Given this list of marker genes Dstn, Arid2, Dnase2b, Ctss (NCBI Gene Id 13040), Smarcd1, Upf1, Smarca4, Add3, Clasp1, Specc1l, Plaat3, Calm1, Ptrh1, Tpx2, Trip4, Nckap5l, Clasp2, Stx17, Ddr1, Taok1, Add2, Tbc1d25, Oga, Calm3, Stmn4, Capza1b, Arhgef2, Ascc3, Myh9, Hpn, Snx14, Kdm4a, Lmod2, Cracd, Ascc2, Capza2, Smarcb1, Gabarapl1, Tnf, Chmp6, Nav3, Ccn2, Map6d1, Itgb1, Pbxip1, Vps16, Ssrp1, Capg, Tecpr1, Trpv4 (transient receptor potential cation channel, subfamily V, member 4), Plekhh2, Atg14, Kif19a, Rpl23, Adamts5, Gbf1, Arid1a (NCBI Gene Id 93760), Fyco1, Diaph3, Becn1, Smarcd3, Iqsec1, Plk3, Hsf1, Fgfr4, Eml4, Camsap3, Atad2, Capza3, Ccsap, Cib1, Denr, Twf1, Kat5, Irak3, Tom1, Twf2, Hbs1l, Dyrk3, Rhoa, Nckap5 (NCK-associated protein 5), Dnase2a (deoxyribonuclease II alpha), Igf1r, Rack1, Hemk1, Pafah1b1, Wdr72, Aurkb (aurora kinase B), Trem2, Acvr1c, Tgfb2, Etf1, H2ac25, Elp6, Gak, Atad2b, Asb17, Vangl2, Chmp7, Chmp1b, Adamts15, Kif18a, Ctsg, Mical2, F2rl1, Top2a, Mfsd8, Prickle1, Trnt1, Cx3cr1, Ufl1, Exog, Fap (NCBI Gene Id 14089), Ltn1, Calm2, Cd47, Insr, Lmod3, Napa, Tcf25, Irgm2, Cdk5rap3, Hspa8, Katnb1, Pym1, Ogfod1, Lcp1, Nsf, Tmem39a, Vrk1, Eif2d, Camsap1, Sh3pxd2b, Svil, Chmp4b, Blcap, Cma1, Col6a1, Kif2c, Akap8l, Cfl1, Map1lc3b, Adrb2, Add1, Chmp2a, Mtrf1, Sema5a, Igtp, Irgm1, Plin2, Mcoln1, Ehbp1l1 (EH domain binding protein 1-like 1), Ankzf1, Plaat1 (phospholipase A and acyltransferase 1), Gsn, Tmod1, Rp1, Chmp1a, Cdk1, Klk5, Lamp2, Atr, Trim58, Gas2l2, Adgrb3, Pik3r1, Map2 (microtubule-associated protein 2), Mical1, Rac1, C1qb, Htt, C1ql1 (NCBI Gene Id 23829), Gata5, Trim21, Hnf1a, Elac1, Plxnc1, Uvrag, Mrpl58, Zfp598, Wnk1, Apc, Hspa2, Skic8, Scaf4, Gas2l1, Lamc1, Mid1ip1, Wdr1, Sptan1, Vmp1, Vil1, Tpm1, Rdx, Aqp2, Sptbn1, Hdgfl3, Ufsp2, Gcn1, Kcnk13, Aurka, Aifm1, Chmp1b2, Plin3, Stmn1, Smarcd2, Avil, Ccdc88c, Tfip11, Rubcnl, Skic3, Bbof1, Ets1, Ppp1r9b, Snai2, Rsph6a, Eef2k, Il1b, Kif14, Abcc8, Vps33a, Septin7, Pdxp, Map1a, Mid1, Tmod3, Synj1, Smcr8 (Smith-Magenis syndrome chromosome region, candidate 8 homolog (human)), H2bc1, Kif9, Spast, Mrrf, Mcts1, Map1b, Apc2, Atg5 (autophagy related 5), Zfand1, Rrp7a, Cst3, Clec16a, Asph, Sh3bp1, Grwd1, Lima1, Ston1, Noxo1, Bok, Stmn2, Ern2, Gabarap, Scin, Fscn1, Ttbk2, Prkaa1, Meltf, Nrg1, Epg5, Dnajc17, Plk1, Smarcc1, Ddit4 (DNA-damage-inducible transcript 4), Tgfbr1, Trim54 (NCBI Gene Id 78173), Afg2b, Dicer1, Tmod4, Pdpn, Rnf14, Pelo, Cidea, Eif5a2, Endog, Apaf1, Tmod2, Cebpg, Vps54, Foxl2 (forkhead box L2), Klhdc10, Rchy1, Mtrfr, Eif5a, Ddrgk1, Kif2b, Sptb, Scaf8, Chmp2b, Eps8, Itgam, Pif1, Sgk1, Smarce1, Abce1, Bax, Stmn3, Ndel1, Bnip3, Klk4, Hdac6, Myc, Mtres1, Vps4a, Map1s, Cdk5, Mmp13, Nedd1, Sharpin, Faf2, Cdkn2a, Nmnat1, Atg12, Skic2, Gspt1, Ckap2, Gabarapl2, Bmerb1, Capzb, Cln3, Zmpste24, Kif21a, Dusp3, Dbnl, Mical3, Kif24, Vcp, Map4k4, Lmod1 (NCBI Gene Id 93689), Vps4b, Epha4, Pik3c3, Tnp1, Mtif3 (NCBI Gene Id 76366), Atp2a2, Smn1, Dedd2, Supt16, Capza1 (capping actin protein of muscle Z-line subunit alpha 1), Smarcc2, Chmp4c, Chka, Acin1, Kif5b, Mapre2, Dpp4, Flot1 (NCBI Gene Id 14251), Dctn1, Eng (endoglin), Cd24a, Arf6, C1qc, Snap29, Stx5a, Ddr2, Ngef, Evl (NCBI Gene Id 14026), Kif18b, Mmp20, Gspt2, Gper1, Pex14, Htr1a, Wdr47, Fgf13, Bloodlinc, Ubqln1, Pex5, Lix1l, Nemp1, Rac2, Dmtn, Golga2 (NCBI Gene Id 99412), Mylk3, Traf2, Carmil2, Pnpla2, Fer, Vill, Akap5 (NCBI Gene Id 70774), Arpc2, Vamp8, Dnase1l3, Map1lc3a, Gba1, Pik3r4, Atxn7, Setx, Pik3ca, Swap70, C3, Blvra, Per2, Eif4e2, Saysd1, Calcoco2, Spef1, Klc1, Dffa, Dnajc6, Phf23, Chmp5, Exoc8, Chmp3, Map4, Camsap2, Nemf (nuclear export mediator factor), Mtif2, Spta1, Snapin, Gigyf2, Igfbp3, Usp10, Shfl, C1qa, Napb, Gfm2, Nes, Mtrf1l, Cfl2, Actn2, Prkaa2, Ubqln4, Flii, Mtpn, Dffb, Sarm1, Jmjd4, Smad7 (SMAD family member 7), Nedd9, Plg, Plek, Rubcn, Rnf25, Cltc, Gtpbp2, Il6, Arhgef1, Shroom2, Lix1, Bmyc, Carmil1, Tgfb3, here is a description of the gene set: Mouse Gene Set: GOBP_CELLULAR_COMPONENT_DISASSEMBLY studied in species Mus musculus A cellular process that results in the breakdown of a cellular component.